Given this list of marker genes TRAF6, IRAK4, MYD88, IL1RAP, MAP3K7 (mitogen-activated protein kinase kinase kinase 7), IL33, IRAK1, IL1RL1, here is a description of the gene set: species: Homo sapiens Human Gene Set: GOBP_INTERLEUKIN_33_MEDIATED_SIGNALING_PATHWAY The series of molecular signals initiated by interleukin-33 binding to its receptor on the surface of a target cell, and ending with the regulation of a downstream cellular process, e.g. transcription.